The following is a description of a gene set: Human Gene Set: GSE15659_CD45RA_NEG_CD4_TCELL_VS_RESTING_TREG_DN Gene expression profiles of subsets of CD4+ T cells according to their expression of FoxP3 and CD45RA were compared. FoxP3 is a key transcription factor for the development and function of natural CD4+ regulatory T cells (Tregs). Here we show that human FoxP3+CD4+ T cells are composed of three phenotypically and functionally distinct subpopulations: CD45RA+FoxP3low resting Tregs (rTregs) and CD45RA-FoxP3high activated Tregs (aTregs), both of which are suppressive in vitro, and cytokine-secreting CD45RA-FoxP3low non-suppressive T cells. The proportion of the three subpopulations characteristically altered in cord blood, aged individuals, and patients with immunological diseases. Terminally differentiated aTregs rapidly die while rTregs proliferate and convert into aTregs in vitro and in vivo as shown by the transfer of rTregs into NOD-scid-common gamma-chain-knockout mice and by TCR sequence-based T cell clonotype tracing in peripheral blood of normal individuals. Taken together, the dissection of FoxP3+ cells into subsets enables one to analyze Treg differentiation dynamics and interactions in normal and disease states, and to control immune responses through manipulating particular FoxP3+ subpopulations. species: Homo sapiens Genes down-regulated in comparison of PTPRC- CD4 T cells versus PTPRC+ resting regulatory T cell (Treg). from publication Miyara M, Yoshioka Y, Kitoh A, Shima T, Wing K, Niwa A, Parizot C, Taflin C, Heike T, Valeyre D, Mathian A, Nakahata T, Yamaguchi T, Nomura T, Ono M, Amoura Z, Gorochov G, Sakaguchi S (PMID 19464196), and this is the list of marker genes: SDC3, THOC6, SSH2, ENTR1, SNORA65, RTP3, ZDHHC15, SRRM1, UTP6, TMEM97, RRAGB, USP34, TGM6, ZNF268, STK25, ZNF430, RBM41, PRPF39, UBE2U, TOP3A, RHBDL2, SP140L, SKI, THBD, PSTK, ZNF579, SULT1B1, UTP23, VEGFB, SEMA7A, ZNF663P, TLCD1, STK32A, ZAN, SMAP2, TRPM6, PROM1, USP7, PUSL1, SPACA7, ZNF277, YRDC, TNNC1, SMC1A, WDR74, PUS7, TRAK1, SLC8B1, RPS6KB1, UBR3, ZSCAN9, SPATA22, TNFSF12, SUN1, ZDHHC8BP, TAS2R9, RAB11FIP4, SAMD12, WAPL, ZSCAN29, ZNF44, RPS3A, SLC43A3, ZNF285, YY1, TSNARE1, ZNF354C, TTLL13, RABGAP1, SCN8A, ZFAND5, RAB43, UMPS, REM2, RNF141, TMSB4Y, SPATA7, SNHG4, SCARNA2, SNHG12, TCN2, TELO2, TRIP11, ZIC1, PRR9, SRL, SF3B1, RIT1, WNT9B, ZNF287 (zinc finger protein 287), ZNF585B, REPIN1, PSKH2, TTC12, SUSD4, TP53, TEX2, ZSCAN26, ZNF687, TCEA3, SLC35E2A, TOMM70, STC2, SDCCAG8, SLC6A7, ZMIZ2, ZNF644, TBX3, TMEM220, SCGB3A2, RTP1, ZNF655, UCN, RPE65, TLN2, SPDYA (NCBI Gene Id 245711), TTLL12, TMCO6, ZFP69B, YIPF2, SPCS2, RIPPLY2, THBS2, TMEM125, SEMA6A, TPMT, CFAP44, VIPR2, TMLHE, SARS2, SLC4A11, TRIM36, RPAIN, SP6, ZNF786, USP43, ZNF346, RRM2B, TMEM70, SMG5, TUBGCP3, SLC43A2, SEH1L, ZNF131, TIMM23B, WDR89, SYN2, TLL2, TLX3, WDR91, ZCCHC13, WDR4, SHANK2, HACD3, ZNF324B, ROS1, SHB, PUM2, TNR, S100A16, ST7-AS1, SLC45A1, SNAP91, ZNF665, TSC22D2, SLFNL1, SLC35D1, TFDP2, TTC4, SLC9A8, WDR90, SUCLG2, USP9X, SCARF2, RPS17P5, SGSM2, PSPN, ZNF394, ZNF596, VASN, TUSC2, TBC1D10A, SGO2, SEPTIN3, ZNF557, SLC16A11, RGL3, SETD1B, SPATC1, ZNF341, TSGA10, SSR2, TGIF2LY, SETD6, TRIM54, TBC1D4, KRBOX5, RPL3L